The following is a description of a gene set: species: Homo sapiens Toll-like Receptor Cascades Human Gene Set: REACTOME_TOLL_LIKE_RECEPTOR_CASCADES, and this is the list of marker genes: IRF5, ITGB2, PIK3R4, MAPK3, MAPK8, PPP2CA, RIPK2, UBE2D1, CTSV, IRF7, DNM3, SFTPA2, IRAK2, RPS27A, CD14, PLCG2, NLRC5, NLRX1 (NCBI Gene Id 79671), TLR1 (toll like receptor 1), NKIRAS2, MAP2K1, IKBKG, UBC, LBP, S100A12, MYD88, CNPY3, MAP3K8, MAPK14, SKP1, IRF3, NFKBIA, RELA, TRAF6 (NCBI Gene Id 7189), PELI3, SOCS1, TLR4, TAB3, TICAM1 (NCBI Gene Id 148022), ITGAM, DUSP6, MAP2K7, IKBKE, TBK1, ELK1, TLR9, TP53, UBE2V1, CD36, NKIRAS1, TLR5, MAPK10, MAP2K3, RPS6KA2, SFTPA1, TRAF2, HSP90B1, CD180, SIGIRR, RIPK1, CTSB (NCBI Gene Id 3896), DUSP7 (dual specificity phosphatase 7), APOB, TASL, IKBKB, TRAF3, LGMN, TLR2, BTRC, TICAM2, TIFA, TLR8, NOD2, LY96, TLR6, ECSIT, NFKB2, N4BP1, FADD, DUSP3, BIRC2, PPP2CB, USP14, IKBIP, ATF1, UBB, BPI (NCBI Gene Id 671), VRK3, BIRC3, S100B, S100A9, TLR7, FGA, PPP2R5D, MAPKAPK2, UBE2N, UBA52 (NCBI Gene Id 7311), DNM1, TAB1, TNIP2, JUN, IRAK3, MAPK11, TAB2, RBSN, PELI2, FGG, AGER, MAP3K7, NFKB1 (nuclear factor kappa B subunit 1), IRAK4, UBE2D3, RPS6KA5, CTSK, GSDME, TLR10, PTPN4, CHUK, TIRAP, OPTN, CTSS, EEA1, MAP2K4, FBXW11, FOS, LY86, LRRC14, TANK (TRAF family member associated NFKB activator), S100A8, RPS6KA1, MAP2K6, SFTPD, MAPK7, RIPK3, GSDMD, CASP8, TLR3, PTPN11, FGB, PIK3C3, MEF2A, CREB1, PPP2R1B, UBE2D2, MAPK1, MAPKAPK3, HMGB1, NOD1, S100A1, MAPK9 (mitogen-activated protein kinase 9), UNC93B1, CTSL, PELI1, ATF2, ALPK1, APP (amyloid beta precursor protein), SARM1, SLC15A4, IRAK1, MEF2C, MAP3K1, RPS6KA3, SAA1, USP18, DNM2, CUL1, NFKBIB, BTK, DUSP4, PPP2R1A